The following is a description of a gene set: species: Homo sapiens Human Gene Set: WP_INTERLEUKIN1_IL1_STRUCTURAL_PATHWAY Interleukin-1 (IL-1) structural pathway, and this is the list of marker genes: IL1A, CHUK, TAB2, EIF4E, RELA, TAB3, MAP3K14, MKNK2, TANK, IL1RAP, ATF2, MAPK14 (NCBI Gene Id 1432), MAP2K7, IRF7, IKBKB, IRAK1, MAP2K1, MAPK3, MAP3K7, MAP2K6, MAP2K3, NFKBIA, MAP3K8, TRAF6, ELK1, TAB1, MBP, TOLLIP, RPS6KA5, MYC, MAPKAPK2, NFKB1, SAFB, MAP2K4, IL1R1, MAPK10, MAP3K3, MAP2K2, MAPK11, MAPK9, MAPK1, FOS, MKNK1, NFKBIB, IRAK2, MYD88, MAPK8, IRAK4, MAP3K1